Given this list of marker genes MIR495, RAMP2, NFE2L2, HLA-G, MIR106B, PDPK1, GPER1, ECSCR, MIR24-1 (microRNA 24-1), PRKCI, FGA, GATA2, FGG, NGFR (NCBI Gene Id 4804), CD40, MIR126, GATA3, PAK4, RGCC (NCBI Gene Id 730127), BMPR2, TEK, ANGPT1, SEMA5A, XBP1, BRAF (NCBI Gene Id 673), F3, ANGPTL4, MIR15A, CD40LG, ABL1, TGFB1, FOXO3, MIR30B, GAS6 (growth arrest specific 6), NDNF, TERT, MAPK7, TNF, PDCD4, ID1, MIR590, CD248, MIR125A, CD160, MIR375, PLCG1, DAB2IP, ANO6, COL4A3, MIR30E, THBS1, KDR, FUT1, AKR1C3, SCG2, MIR101-1, ITGB3, FASLG, TNFAIP3, KRIT1, IL11, IL13, CCL2, CDH5, MIR132, FGB, SERPINE1, IL10, TNIP2, PTPN1, IL4, ICAM1, HIPK1, ITGA4, MAP3K5, here is a description of the gene set: Any apoptotic process in an endothelial cell. An endothelial cell comprises the outermost layer or lining of anatomical structures and can be squamous or cuboidal. species: Homo sapiens Human Gene Set: GOBP_ENDOTHELIAL_CELL_APOPTOTIC_PROCESS